Given this list of marker genes Ppp1r9b, Filip1l, Luzp1, Filip1, Cttnbp2nl, here is a description of the gene set: A process in which a protein is transported to, or maintained in, the location of an actin cytoskeleton. studied in species Mus musculus Mouse Gene Set: GOBP_PROTEIN_LOCALIZATION_TO_ACTIN_CYTOSKELETON